The following is a description of a gene set: Human Gene Set: GSE27241_CTRL_VS_DIGOXIN_TREATED_RORGT_KO_CD4_TCELL_IN_TH17_POLARIZING_CONDITIONS_UP species: Homo sapiens from publication Huh JR, Leung MW, Huang P, Ryan DA, Krout MR, Malapaka RR, Chow J, Manel N, Ciofani M, Kim SV, Cuesta A, Santori FR, Lafaille JJ, Xu HE, Gin DY, Rastinejad F, Littman DR (PMID 21441909) Genes up-regulated in polarizing CD4 Th17 cells: wildtype untreated versus RORC knockout treated by digoxin. CD4+ T helper lymphocytes that express interleukin-17 (Th17 cells) have critical roles in mouse models of autoimmunity, and there is mounting evidence that they also influence inflammatory processes in humans. Genome-wide association studies in humans have linked genes involved in Th17 cell differentiation and function with susceptibility to Crohn’s disease, rheumatoid arthritis, and psoriasis1-3. Thus, the pathway towards differentiation of Th17 cells and, perhaps, of related innate lymphoid cells with similar effector functions4, 5, is an attractive target for therapeutic applications. Mouse and human Th17 cells are distinguished by expression of the retinoic acid receptor-related orphan nuclear receptor RORγt, which is required for induction of IL-17 transcription and for the manifestation of Th17-dependent autoimmune disease in mice6. By performing a chemical screen with an insect cell-based reporter system, we identified the cardiac glycoside digoxin as a specific inhibitor of RORγt transcriptional activity. Digoxin inhibited murine Th17 cell differentiation without affecting differentiation of other T cell lineages and was effective in delaying the onset and reducing the severity of autoimmune disease in mice. At high concentrations, digoxin is toxic for human cells, but non-toxic synthetic derivatives, 20,22-dihydrodigoxin-21,23-diol (Dig(dhd)) and digoxin-21-salicylidene (Dig(sal)), specifically inhibited induction of IL-17 in human CD4+ T cells. Using these small molecule compounds, we demonstrated that RORγt is imporant for the maintenance of IL-17 expression in mouse and human effector T cells. These data suggest that derivatives of digoxin can be used as chemical probes for development of RORγt-targeted therapeutic agents that attenuate inflammatory lymphocyte function and autoimmune disease., and this is the list of marker genes: LINC00926, HSD17B6, GOLGA3, ODF2L, FAM226B, CENPN, LECT2, ZNF444 (NCBI Gene Id 55311), ZC4H2 (NCBI Gene Id 7493), ZGRF1, PPIA, GEN1 (NCBI Gene Id 348654), ADA, KATNAL1, RIC8B, FRMD3, KLF13, CD1C (CD1c molecule), KIF18B, PKN3, TTC7A, IRAG2, BLTP3A, DNTT, UBL7-DT, CD1E, PTGDR2, MZB1, KCNA2, PLEKHG1, INSIG1, ALG5, TFDP2, HMGB3, KIF11, TRIM41, EFCAB7, SLC38A4-AS1, H2AC11, CTNNAL1, TROAP, KIF23, CKAP2L, CBFA2T3, HMGB2 (high mobility group box 2), CAPN7 (calpain 7), LINC00938 (long intergenic non-protein coding RNA 938), GPR180, NSD2, NDUFC2, EFHC1, TCF3, SPRY1, GKAP1, ARHGEF18 (NCBI Gene Id 85008), AIFM1, MELK, MIS12, CRY1, DDB2, FGFR3, HADH, CEP152, CD52, GSR, BMF, HKDC1, C8orf88, PET100, PLXND1, ARL6IP1, KNTC1, SNRK, RHEB, ARHGAP11A, WDR76, CD1D, DCUN1D2, FAM53B (family with sequence similarity 53 member B), WDR19, FECH, ZBTB18, RBM33 (NCBI Gene Id 92454), CD8B, IKZF2, CD2AP, PTPN2, SKA2, TRIM59, POLI, SMPD3, TRIM62, CALCOCO1 (NCBI Gene Id 57658), VEZF1, WDR90, RFC5, ERI2, SPEN, SAPCD2, PLA2G15, ISCU, WHRN, SYNE2, YKT6, SLC12A4, TMCC1, CD38 (CD38 molecule), CHRNB4, PAN2, ITIH4, NT5C2, RCSD1, DDX23, GNA13, MAP2K6, LRCH3, BIN3, MAFK, VAMP7, ZNF709 (zinc finger protein 709), ARHGEF7, STK32B, RIC1, SLAMF1, RDM1, ANLN, GAL3ST4, ACSF3, IQCC, ZNF33B, SLC25A5, PBX4, CCDC28A, ELOVL4, MYBL1, EEPD1, RAG1, LYRM1, CENPV, FAM8A1, RALGPS2, CEP76, BMAL1, BTG2, DNMBP, LSS (NCBI Gene Id 4047), EPB41L2, TUBB3, PURG, MTSS2, DGKE, WDR13 (NCBI Gene Id 64743), ARSK, C18orf54, KCNG3, ARL2BP, PRC1, MIER3, H2BC6, SPC25, RACGAP1 (NCBI Gene Id 94651), SLC25A35, TSPOAP1, RCN2, TCF12, TRPV5, ABHD8, DIAPH3, USP1 (NCBI Gene Id 7398), H2BC7, TSHR, KAT6B, SCAI, TBL1XR1, CTC1, RNASEH2B (ribonuclease H2 subunit B), ANP32E, C4orf46, KPTN, ABCC2, SLC25A46, SRP9, CYP2U1, EGLN3, KIF20A, ATP8B3, TOP2A, GAS8, ARHGAP33, UBN2, CD1B, SLC35A3, MKNK1, CCDC71L, CELSR2, TMPO-AS1, DYM